Given this list of marker genes Slc5a6 (solute carrier family 5 (sodium-dependent vitamin transporter), member 6), Slc26a4, Slc5a5, Mfsd8, Ano1, here is a description of the gene set: studied in species Mus musculus Enables the transfer of iodide ions from one side of a membrane to the other. Mouse Gene Set: GOMF_IODIDE_TRANSMEMBRANE_TRANSPORTER_ACTIVITY